Given this list of marker genes MATN3, SMAD3, LMNA, HGD, TBX1, SMAD2, here is a description of the gene set: Intervertebral disk degeneration studied in species Homo sapiens Human Gene Set: HP_INTERVERTEBRAL_DISK_DEGENERATION The presence of degenerative changes of intervertebral disk.